Given this list of marker genes Dnmt3b, Axin1, Mta2, Dcaf13, Ndn, Tet3, a, Arid4b, Dnmt1, Gnasas1, Gsk3b, Airn, Meg3, Zfp57, Dnmt3a, Smchd1, Zfp445, Tet1, Morc1, Suv39h1, Mecp2, Prdm14, Gsk3a, Trim28, Suv39h2, Dppa3, Arid4a, Tsix, Prmt7, Kdm1b, Ctcf, Zfp42, Mettl23, Mycn, Eed, Gnas, H19, Pik3ca, Kcnq1ot1, Stpg4, Cdkn1c, Ctcfl, Zdbf2, Dnmt3l, Xist, Ddb1, here is a description of the gene set: A epigenetic process that happens during embryonic development that modulates gene expression potential at later stages of development of the organism, including the adult. Epigenetic regulation takes place via chromatin remodeling either by modifying higher order chromatin fiber structure, nucleosomal histones, or cytosine DNA methylation. species: Mus musculus Mouse Gene Set: GOBP_EPIGENETIC_PROGRAMMING_OF_GENE_EXPRESSION